Given this list of marker genes Ube2k, Trim6, Ube2srt, Ambra1, Rnf135, Prkn, Trim32, Ube2s, Ube2c, here is a description of the gene set: The process of creating free ubiquitin chains, compounds composed of a large number of ubiquitin monomers. These chains are not conjugated to a protein. species: Mus musculus Mouse Gene Set: GOBP_FREE_UBIQUITIN_CHAIN_POLYMERIZATION